Given this list of marker genes Hmx2, Hspa8, Upf1, Slc38a2, U2af2, Zfp64, Slc39a5, Prdx6, Hnrnpll, Slirp, Ncl, Upf3a, Srsf5, Smn1, Rbmxl1, Eif1, Ern1, Pik3r1, Tra2a, Rbm3, Hnrnpk, Dyrk1a, Rbmyf3, Rbm20 (RNA binding motif protein 20), Dazap1, Prpf19, Srsf1, Snw1, Zpr1 (NCBI Gene Id 22687), Rbm22, Obi1 (NCBI Gene Id 72486), Cirbp, Nup98, Clns1a, Prdx6b, Eif4a3, Celf3, Gm7324, Rbmyf9, Khdrbs3, Setx, Rbmyf6, Thrap3, Polr2a, Snrnp70, Celf4, Ncbp1, Rbmyf1, Habp4, Prmt5, Upf3b, Rbmxl2, Wdr77, Rbmx, Exosc10, Lmntd2, Tra2b, Rbmy, here is a description of the gene set: studied in species Mus musculus Mouse Gene Set: GOBP_POSITIVE_REGULATION_OF_RNA_SPLICING Any process that activates or increases the frequency, rate or extent of RNA splicing.